The following is a description of a gene set: Mouse Gene Set: MIR_7077_5P Genes predicted to be targets of miRBase v22 microRNA mmu_miR_7077_5p in miRDB v6.0 with MirTarget v4 prediction scores > 80 (high confidence targets). from publication Chen Y, Wang X (PMID 31504780) studied in species Mus musculus, and this is the list of marker genes: Vwc2, Apela, Cyp4a10, C1qtnf1 (NCBI Gene Id 72004), Ndnf, Neto2, Otub2, Ube2h, Rapgef6, Khdc4, Arhgap1, Slc7a11, Mtfr1l, Sh3pxd2a, D7Ertd443e, Ttyh3, Actrt1, Atg7, Irs1, Satb2, Prrg3, Dtna, Elmod1, Caln1, Cyb561, Plcxd2, Tfap2a, Slc2a13, Pfkfb2, Zc2hc1c, Sfpq, Map6, Batf2, 2310022A10Rik, Rimoc1, Vps26b, Prrt4, Cd84, Tomm22, Srsf1, Slc39a13, Aak1, Nlgn1, Mief1, Kat2a, Tram2, D130043K22Rik, Cfl2, Cask (calcium/calmodulin dependent serine protein kinase), Zfp318, Shank2 (NCBI Gene Id 210274), Cux1, Yars1, Hoxd1, Fzd4, Igf2bp1, Itgb1, Chd8, Syt9, Ddx3y, Ddx3x, Ccdc160, Pom121, Hk2, Zswim5, Prickle2, Hsf5, Scd3, Pip4k2b, Atxn7l3, Nectin3, Cacng1, Zbtb7c, Mtx3, Faah, Cyp4a31, Angptl2, Krr1, Pes1, Tcf20, Slc46a1, Myd88, Kmt2d, Myc, Trabd2b